Given this list of marker genes Pex14, Pex26, Slc25a17 (NCBI Gene Id 58177), Pex12, Pex16, Acbd5, Fis1, Pex11b, Pxmp4, Abcd1, Aldh3a2 (NCBI Gene Id 11672), Pex19, Abcd2, Abcd3, Gdap1, Pex13, Pex2, Atad1, Pex3, here is a description of the gene set: studied in species Mus musculus Class I peroxisomal membrane protein import Mouse Gene Set: REACTOME_CLASS_I_PEROXISOMAL_MEMBRANE_PROTEIN_IMPORT